Given this list of marker genes PTPN18, DDAH2, AZGP1, TRPM5, SOX4, AOC1 (NCBI Gene Id 26), ATP2A3, AVIL, RASSF6, SPINK5, SH2D6, IRAG2, here is a description of the gene set: Human Gene Set: BUSSLINGER_GASTRIC_TUFT_CELLS from publication Busslinger GA, Weusten BLA, Bogte A, Begthel H, Brosens LAA, Clevers H (PMID 33691112) species: Homo sapiens